The following is a description of a gene set: Mouse Gene Set: GOBP_REGULATION_OF_MYOBLAST_PROLIFERATION species: Mus musculus Any process that modulates the frequency, rate or extent of myoblast proliferation., and this is the list of marker genes: Zfp609, Pax7, Ppard, Tbx18, Gata6, Sox15, Mstn, Six1, Ankrd2, Myod1, Meis2, Fgf7, Ctnnb1, Neu1, Paxbp1, Fgfbp1, Csf1r, Megf10, Igf1, Malat1, Kcna5, Atf2, Snhg15, Klhl41